Given this list of marker genes BHLHA9, BMPR1B, FGFR2, MYCN, RUNX2, ERF, GDF5, BMP2, SRCAP, INTU, IFT140, KIF15, COL2A1 (NCBI Gene Id 444981), HOXD13 (NCBI Gene Id 7859), FIG4, TBX5, NSDHL, TWIST1, here is a description of the gene set: Human Gene Set: HP_ABNORMALITY_OF_THE_PHALANGES_OF_THE_2ND_FINGER Abnormality of the phalanges of the 2nd (index) finger. Abnormality of the phalanges of the 2nd finger species: Homo sapiens